Given this list of marker genes Fn1, S100a11, Ctsd, Lamc1, Fbln5, Hspg2, Lama5, Col6a1, Col6a2, Mfap4, Lamc2, Lamb3, Lamb2, Nid1, Fgb, Emilin1, Lama3, Ogn, Postn (periostin, osteoblast specific factor), Tnc, here is a description of the gene set: Mouse Gene Set: NABA_MATRISOME_BLEO_FIBROTIC_LUNG species: Mus musculus In this study, we investigated the role of the extracellular matrix (ECM) in the underlying biology of lung adenocarcinoma using an autochthonous mouse model that recapitulates the complexity of cancer initiation and progression to characterize the ECM composition of normal lung, fibrotic lung, lung tumors, and metastases. We isolated normal, healthy lung tissues from wild-type (WT) mice and microdissected KrasG12D/p53-/- primary lung tumors (KP tumors) and associated metastases to the mediastinal lymph node. Quantitative mass spectrometric profiling of the ECM composition of normal lung, fibrotic lung (from bleomycin-treated mice), primary lung tumors, and lung metastases to the lymph nodes uncovered specific signatures distinguishing these tissues. This gene set lists the matrisome proteins detected in significantly different abundance in lung fibrosis as compared to normal lung. from publication Gocheva V, Naba A, Bhutkar A, Guardia T, Miller KM, Li CM, Dayton TL, Sanchez-Rivera FJ, Kim-Kiselak C, Jailkhani N, Winslow MM, Del Rosario A, Hynes RO, Jacks T (PMID 28652369) Matrisome proteins detected in significantly different abundance in lung fibrosis as compared to normal lung.